Given this list of marker genes IGHV3-11, VAV2, APP, ABL1, IGLV3-27, MAPK8, PRKACG, HCK, IGLV6-57, IGLV1-51, GNAZ, IL6, ITPR2, IGHG1, IGKV1-16, NLRP3, IGLC2, IGLV2-14, IGKV1-12, ADCY6, ACTR2 (NCBI Gene Id 10097), GNAI3, ENTPD1, IGHG2, CYBA, GNG12, PRKX, IGKV1-17, ITPR3, ADCY2, GNG4, WASF1, FZD7, PRKAR2A, IGLV3-1, MYO5A, IL10, GGT5, DVL3, GNGT2, MEFV, MYH9, PTK2, HSP90AB1, MAPK1, ADCY1, CD163, PSTPIP1, CYSLTR2, ACTB, IGLV2-8, GNB2, IGLV1-47, IGLV2-11, ACTG1, JUN, CTSG, CYFIP1 (cytoplasmic FMR1 interacting protein 1), ELMO2, GNG13, BRK1, IGKV2D-40, AHCYL1, CDC42, VAV1 (vav guanine nucleotide exchange factor 1), GNG8, IGKV2-30, GNAI2, IGKV1D-39, RHBDF2, GNAS, ADCY4, NOXO1, C3, PLCG1, P2RX4, IGKV2-28, IGHV4-39, WIPF3, IGKV1D-16, IGKV3-15, ADCY5, ADORA2B, IL1B, IGLC3, PYCARD (PYD and CARD domain containing), WASF3, YES1, FYN, MYO9B, CREB1 (NCBI Gene Id 1385), IGHV3-30, WASL, IGLV2-23, LYN, MYH2, DOCK1, ITPR1, NCKAP1L, IGHV1-46, ADCY9, ABI2, NFKB2, ADCY3, FURIN, GNG3, IGLV1-44, ARPC2, IGKV3-11 (NCBI Gene Id 28914), ADAM17, ELMO1, IGHV4-59, IGHV3-33, NCK1, IGHV1-2, IGKV4-1, GNB4, ACTR3 (actin related protein 3), MAPK14, FCGR1A, IGHV3-13, IGKV1-39, NOXA1, IGHV3-7, IGKV1-5, CRK, ARPC1B, ENTPD5, BAIAP2, ADCY8, GNG5, DVL1, DVL2, ADCY7, GNG10, SRC, PLCG2, VAV3, SYK (spleen associated tyrosine kinase), NCKAP1, IGHV4-34 (NCBI Gene Id 28395), IL18, MAPK3, NOX1, HMOX1, CASP1, ABI1, TXN, WIPF1, BTK, GNAT3, GNG11, RAC1, IGKV3-20, IGKV3D-20, IGHV2-5, DPEP1, SUGT1, IGKV1-33, GNAI1, ARPC4, GNG7, ARPC1A, GRB2, GNG2, IGLV3-25, C3AR1 (NCBI Gene Id 719), RELA, GNB3, IGHV1-69, IGLV3-21, PRKAR1A, CD3G, NT5E, IGHV2-70, IGKV5-2, IGHV3-48, CALM1, CD247, WNT5A, WIPF2, FCGR2A, GNB1, GNGT1, GNB5, PRKAR2B, CYFIP2 (cytoplasmic FMR1 interacting protein 2), IGHV3-53, IL1A (interleukin 1 alpha), NFKB1, IGLV7-43, IGLV3-19 (NCBI Gene Id 28797), IGKV2D-28, FCGR3A, WAS, ARPC5, PLK2, PRKAR1B, IGHG4, PRKACB, MYO10, DPEP2, GSDMD, TXNIP, IGKV1D-12, MYO1C, WASF2, GGT1, IGKV2D-30, ARPC3, IGKV1D-33, CYSLTR1, NCKIPSD, P2RX7, FGR, PRKACA (protein kinase cAMP-activated catalytic subunit alpha), IGLV1-40, IGHV3-23, here is a description of the gene set: species: Homo sapiens Leishmania infection Human Gene Set: REACTOME_LEISHMANIA_INFECTION